The following is a description of a gene set: Genes which best discriminate between two groups of breast cancer according the status of ESR1 and AR: apocrine (ESR1- AR+) vs basal (ESR1- AR-). Human Gene Set: FARMER_BREAST_CANCER_APOCRINE_VS_BASAL from publication Farmer P, Bonnefoi H, Becette V, Tubiana-Hulin M, Fumoleau P, Larsimont D, Macgrogan G, Bergh J, Cameron D, Goldstein D, Duss S, Nicoulaz AL, Brisken C, Fiche M, Delorenzi M, Iggo R (PMID 15897907) species: Homo sapiens Previous microarray studies on breast cancer identified multiple tumour classes, of which the most prominent, named luminal and basal, differ in expression of the oestrogen receptor alpha gene (ER). We report here the identification of a group of breast tumours with increased androgen signalling and a 'molecular apocrine' gene expression profile. Tumour samples from 49 patients with large operable or locally advanced breast cancers were tested on Affymetrix U133A gene expression microarrays. Principal components analysis and hierarchical clustering split the tumours into three groups: basal, luminal and a group we call molecular apocrine. All of the molecular apocrine tumours have strong apocrine features on histological examination (P=0.0002). The molecular apocrine group is androgen receptor (AR) positive and contains all of the ER-negative tumours outside the basal group. Kolmogorov-Smirnov testing indicates that oestrogen signalling is most active in the luminal group, and androgen signalling is most active in the molecular apocrine group. ERBB2 amplification is commoner in the molecular apocrine than the other groups. Genes that best split the three groups were identified by Wilcoxon test. Correlation of the average expression profile of these genes in our data with the expression profile of individual tumours in four published breast cancer studies suggest that molecular apocrine tumours represent 8-14% of tumours in these studies. Our data show that it is possible with microarray data to divide mammary tumour cells into three groups based on steroid receptor activity: luminal (ER+ AR+), basal (ER- AR-) and molecular apocrine (ER- AR+)., and this is the list of marker genes: MSX2 (NCBI Gene Id 8053), PMAIP1, PAM, PRR15L, SYCP1, CASD1, MID1, CYP2J2, ELOVL5, TPGS2, EFHD1, ZKSCAN1, ACE2, SNRPD1, PAPSS2, GNMT, NR2F1, E2F3, PLAGL1, PLSCR1, ACOX2, MYC, SERHL, SELENOP, GPX7, DCXR, SPRED2, BTBD3, SCD (stearoyl-CoA desaturase), FAM174B, ENSG00000291006, PRKAA1, MTUS1, HGD, ECHDC1, LRRC8D, GHR, DHCR24, UBE2C, ANKLE2, BLVRB, GGT1, RHOB, SYNCRIP, PPIC, DUSP10, KIF18B, GSTZ1, GINS1, APOBEC3A, LYN, AR, ETFB, LONP2, CDC42EP3, S100A2, AZGP1, NUP88, FEM1C, TMEM87A, GFUS, PKP1, SCNN1A, LBR, FBL, SH3BP4, YEATS2, TTLL12, PLEKHB1, RBBP8, LMO4, MLPH, GALE, TRMT11, FMO5, SLC2A10, ERLIN2, AGPS, FJX1, NAV2, ETFA, BCAP29, UPF3B, G6PD, TFAP2B, BRINP3, ACSS3, ESRRG, SLC19A2, MAPT, CLCA2, REEP5, MSMO1, AKR1D1, HSPA6, CX3CL1, TMEM135, ARFIP2, STIL, PREP, LIMCH1, TAF1A, S100A6, UCP2, RABEP2, SEPHS2, STOML2, PDCD5, TRPV6, SREBF1, CRAT, KCNMA1, HOXB2, ENOSF1, SEC23B, ACAD8, KYNU, HMGCR, CCL2, KDM4B, PIK3R1, CYB5A, DSC3, LDHB, PROM1, ANP32E (NCBI Gene Id 81611), ACSL3, CCDC88A, ACACA, CLN3, SEL1L3, SPTLC2, CYP4F8, MYL6B (NCBI Gene Id 140465), NT5C2, S100A4, C1QBP, AKR1A1, QSOX1, AK4, ALCAM, CADPS2, GPM6B, SWAP70, KLF5, CDKN2A, KRT16, PON2, SLC26A3, ABCC6, TNFRSF21, PLCL2, KIF20A (kinesin family member 20A), NHERF1, OPTN, P2RY2, HPRT1, TYMS (thymidylate synthetase), AMACR, TPD52, MAOA, KRT6B, PIP, FAM234B, TP53TG1, BMERB1, GSPT2, APOD, CDH1, CHST1, PELI1, LRBA, PGRMC2, PCLO, QKI, RASGRP1, ATP11B, TCF7L2, TAF5, HACD3, TSC22D3, MKNK2, NEDD4, CYB561, TRAK2, ADCY7, SIK1, APLP2, CYP51A1, TTC13, MAGED2, P4HA1, ELAPOR1, FASN, TRIM36, TMPRSS2, ALDH3B2, SLC16A1, TRIL, FCN2, UTP25, GPR161, SOCS5, CCNDBP1, ZWILCH, ZBTB16, CTBS, S100A13, KMO, GLS, TASOR2, FOXC1, PSIP1, HMGCS2, SIDT1, PLAAT2, CRIPT, SIGLEC15, DCAF6, IDH2, TMEM158, DHRS2, PUM3, SPDEF, SLC22A18, FMR1, ZMYND8, KANK1, HERC5, FDFT1, VWA5A, KIF14 (NCBI Gene Id 9928), NRAS, RBM47, SLC38A1, STK26, MELK, GSE1, KRT18, TSPAN3, RGS10, ERBB4 (erb-b2 receptor tyrosine kinase 4), TUBB6, TOP2A, SCHIP1, BBS1, ACSL1, CIRBP, PFDN4, PTK6, TMEM41B, UBE2E3, CES1, PRKX, CLGN, TSPAN13, RNF138, MKI67, ABCC5, PDLIM1, ECHDC2, KIF23, RETSAT, CROT, FAM216A, CLU, GPD1L, CLDN8, UGT2B11, IDH1, BCL11A, SERHL2, GGTLC1, CDC20, EN1, PRKACB, LIMA1, BMAL2 (basic helix-loop-helix ARNT like 2), DMD, RND1, DALRD3, SC5D, LAMP3, AKAP9, ATP6V1G1, BTG3 (BTG anti-proliferation factor 3), GABRP, MPHOSPH6 (NCBI Gene Id 10200), MFAP2, TP53BP2, MLF1, CEP55, ABHD11, KIT (NCBI Gene Id 5086), PNISR, FABP5, ABCA12, CLDND1, CNTNAP2, HMGN4, KIF11, KRT7, OBI1, PRKAR2B, ATP7A, KRT6A, NAAA, DUSP4, NCK1, SLC35A3, EGF, DAP, IDI1, ANKRD27, PHKB, GALNT7, SAR1B, CRISP3, CERS6 (ceramide synthase 6), UGDH, DBI, PRLR, NANS, IGF2BP2, RNF141, PEX11A, FAH, INPP4B, CERS4